Given this list of marker genes Slc17a9, Bhlhe23, Gm14413, Zfp966, Prpf6, Rps21, Gm14496, Gm14434, Gm14326, Zbtb46, Stmn3 (stathmin-like 3), Cdh26, Helz2, Mir296, Gm14407, Tcea2, Slc2a4rg-ps, Vapb, Gm14390, Phactr3, Polr3k, Gm14305, Ntsr1, Gm14428, Zfp512b, Gm14417, Gm14404, Gm14445, B230312C02Rik, Ptk6, Prelid3b, Zfp967, Ythdf1, Dido1, Gm2004, Gnasas1, Nelfcd, Gm14371, Vamp7-ps, Gm14443, Samd10, Gm14288, Ss18l1, Gm14421, Gm14340, Zfp831, Abhd16b, Gm14414, Gm2007, Ppdpf, Edn3, Ppp1r3d, Atp5k-ps2, Atp5f1e, Gm14405, Gid8, Psma7, Mir124a-3 (microRNA 124a-3), Gm14344, Gm14403, Cables2, Gm14617, Gm27032, Cdh4, Vmn1r-ps1, Lsm14b, 9230112E08Rik, Uckl1, Mtg2, Zfp968 (zinc finger protein 968), Birc7, Chrna4, 4930591A17Rik, Fam217b, Gm14444, Gm16357, Gm4724, Arfrp1, Gm10714, Mir6340, Gm14308, Zgpat, Zfp965, Gm24892, Zfp1010, Mir1a-1, Gm25184, 2210418O10Rik, Mir3091, Gm2020, Gm14419, Gm14439, Pcmtd2, Gm14294, Rbbp8nl, Fndc11, Arfgap1, 4921531C22Rik, Sycp2, Col9a3, Rtel1, Lama5, Tubb1 (tubulin, beta 1 class VI), Slco4a1, Gm11007, Gm14391, Gm14343, Npepl1, Zfp971, Ctsz (cathepsin Z), Zfp931, Gm14295, Tcfl5, Gm14416, Gm2026, Gm14324, Lkaaear1 (NCBI Gene Id 277496), Gm14314, Zfp1009, Gm14322, Gm18917, Zfp969, Gm14400, Dnajc5, Zfp968-ps, Mrgbp, Taf4, Zfp973, Gm14401, Gm1980, Zfp1003, Zfp970, Kcnq2, Lime1, Gm14342 (predicted gene 14342), Ogfr, Gm4631, Hrh3, Gm11009, Rpl30-ps5, Rgs19, Mir7006, Mir7005, 1700010B08Rik, Stx16, Adrm1, Gm14412, Gm22708, Uckl1os, Gata5, Gm14325, Rps8-ps2, Osbpl2, Gm14336, Gm29797, Gm14411, Gm14418, Gm14438, Rps8-ps5, Gm14489, Gm14406, Gm7645, Gm14393, Gm14387, Gm11008, Gm14399, Gm14292 (NCBI Gene Id 100047730), Gm14296, Sox18, Gm14398, Gm25879, Nkain4, Gata5os, Eef1a2, Gm5466, Mir133a-2, Gm14442 (NCBI Gene Id 100043762), Gm14410, Gm14402, Gm6710, Gnas, Zfp972, Gm14616, Srms, Oprl1, Gmeb2, Mir298, Col20a1, Tpd52l2, Myt1, here is a description of the gene set: species: Mus musculus Mouse Gene Set: chr2H4